Given this list of marker genes SGK1, NEK11 (NCBI Gene Id 79858), TSSK2, LIMK2, MAPK13, RPS6KB1, SRPK1, TTBK1, SRPK3, CDK9, TLK1, MYO3B, CASK, STK39, NEK4, CDC42BPB, C8orf44-SGK3, DCAF1, MAPK9, PBK, BUB1B, MAP3K2, CAMKK2, PRKX, CIITA, MAP3K14, PRKACA, BUB1, EIF2AK1, PAK6, CDK17, SMG1, CAMK1G, MAP2K6, ERN2, CDK1, BRSK2 (BR serine/threonine kinase 2), STK26, LRRK2, EIF2AK2, DYRK4, MAPKAPK5, NEK5, IRAK1, MARK2, PIM1 (Pim-1 proto-oncogene, serine/threonine kinase), BCR, CDK3, HIPK1, MTOR, PRKAA2, CILK1, RIPK4, NEK6, PRKACG, LMTK2, CAMK1, HIPK4, PINK1, WNK4, MAP2K3 (NCBI Gene Id 92079), CSNK1G1, PDIK1L, PRKCB, BRAF, MAPK4, MOK, MAP3K10, CAMK4, STK32A, RPS6KA1, SNRK, MAP3K15, MAP4K2, PNCK, KALRN, EIF2AK4 (NCBI Gene Id 440275), PRKCQ, PRKCH, MAST4, PRKACB, CSNK1G3 (NCBI Gene Id 1456), CDK19, CSNK1A1L, MAP3K8, NEK3 (NCBI Gene Id 4752), AKT3, CDC42BPG, TP53RK, STK36, CDK16, SPEG, TSSK6, CSNK2A3, RPS6KA3, MAPK12, SIK1, DMPK, MAP3K19, STK10, PLK2, MAP3K9, PKN3, TRIO, RIPK3 (receptor interacting serine/threonine kinase 3), MAP2K5, RPS6KA2, PRKDC, STK40, MAP2K2, PRP4K, NEK9, TSSK4, CDK11B, HUNK (hormonally up-regulated Neu-associated kinase), CAMK2D (NCBI Gene Id 817), GAK, CLK1, MAPK1, PGK1, DAPK2, TNK2, PRKCG, LATS1, PRKY, DAPK1, DYRK3, RIPK1, PRKCZ, TAOK3, AAK1, PDPK1, HIPK2, STK25, HASPIN, CDK2, TTBK2, DAPK3, MARK1, PIK3CA, DSTYK, MAP3K20, CDK10, ATR, ERN1 (endoplasmic reticulum to nucleus signaling 1), CDK4, OBSCN, CLK3, PRKCI, MYO3A (NCBI Gene Id 94143), STK3, TRPM6, AATK, PSKH2, PAK5, OXSR1, RPS6KB2 (ribosomal protein S6 kinase B2), CDK7, AURKA, CDK14, MINK1, MAST3, RPS6KA6, MAP2K4, AKT2, CDK11A, ULK3, UHMK1, CDKL5, PRKG1, PKN1, MAP3K21, MAP2K1 (mitogen-activated protein kinase kinase 1), MAP3K11, STK17A, SIK2, TTN, TESK2, SRPK2, MAP4K4, ULK2, RIOK2, PKN2, TLK2, WNK3, NEK2, LRRK1, VRK1, CAMK2B, DCLK3, STK17B, CDK13, AURKC, SIK3, MAP3K12, CDK6 (cyclin dependent kinase 6), BRSK1, MAPK15, TAOK2, STK38, RIOK3, PRKD1, MAP3K13, MAST2, GSK3A, CDKL3, ARAF, CDK12, MAP3K7, TRPM7, PIM2, PIK3CB, STK11, MAPK14, RAF1, CSNK2A2, CDK18, PAK4, CSNK1E, CDKL1, CLK2, PIK3CG, ALPK3, PRKCD (NCBI Gene Id 5580), RPS6KL1, MARK3, CLK4, MAPK11 (NCBI Gene Id 5600), ALPK2, MAPKAPK2, MARK4, BMP2K, RPS6KA5, BCKDK, CAMK2A, RPS6KC1, MAPK8, SLK, TSSK3, MAP3K3, CHEK1, MAP3K5, TAOK1, EIF2AK3, CAMKK1, PKMYT1, PRKD2, MAP3K6, TSSK1B, MAPKAPK3, CDK5, CDC42BPA, PASK, ULK4, MAST1, PIM3, CAMK2G, NEK1, STK32C, LATS2, MAP2K7, ALPK1, PIKFYVE, CDC7, KSR2, PRKCA, PIK3R4, PAK3, TNNI3K, MAP4K3, MAP3K4, MAPK3, NLK, CDK15, GSK3B, ANKK1, PAK2, STK16, MAK, MAP4K5, NEK7, ATM, CDK20, CSNK1G2, PRKAA1, HIPK3, STK33, WNK2, TNIK, FASTK, IKBKB, DYRK2, MAPK10, FAM20C, NEK8, CSNK2A1, PLK3, TTK, RSKR, WNK1, NRK (NCBI Gene Id 203447), STK24, MYLK4 (NCBI Gene Id 340156), MELK, PSKH1, PAK1, CAMK1D, SBK3, LMTK3, ROCK1, AURKB, RPS6KA4, DCLK2, CDKL4, DCLK1, STK35, LIMK1, PLK4, NIM1K, CSNK1D, PRKCE, PRKD3, MKNK1, DYRK1B, PLK1, PRKG2, CIT, KSR1, TAF1, STK4, VRK2, DYRK1A, NEK10, AKT1, STK38L, SBK1, RIPK2, CDKL2, ULK1, SGK2, MAPK7, CDK8, TBK1, MOS, SBK2, MAP4K1, RIOK1, PHKG1, MKNK2, MASTL, IRAK4, SGK3, MAPK6, ROCK2, CHEK2, NUAK2, TESK1, MAP3K1, STK31, STK32B, NUAK1, CSNK1A1, here is a description of the gene set: Human Gene Set: GOMF_PROTEIN_SERINE_KINASE_ACTIVITY Catalysis of the reactions: ATP + protein serine = ADP + protein serine phosphate. species: Homo sapiens